The following is a description of a gene set: Human Gene Set: TESAR_ALK_TARGETS_HUMAN_ES_4D_DN The application of human embryonic stem (ES) cells in medicine and biology has an inherent reliance on understanding the starting cell population. Human ES cells differ from mouse ES cells and the specific embryonic origin of both cell types is unclear. Previous work suggested that mouse ES cells could only be obtained from the embryo before implantation in the uterus. Here we show that cell lines can be derived from the epiblast, a tissue of the post-implantation embryo that generates the embryo proper. These cells, which we refer to as EpiSCs (post-implantation epiblast-derived stem cells), express transcription factors known to regulate pluripotency, maintain their genomic integrity, and robustly differentiate into the major somatic cell types as well as primordial germ cells. The EpiSC lines are distinct from mouse ES cells in their epigenetic state and the signals controlling their differentiation. Furthermore, EpiSC and human ES cells share patterns of gene expression and signalling responses that normally function in the epiblast. These results show that epiblast cells can be maintained as stable cell lines and interrogated to understand how pluripotent cells generate distinct fates during early development. species: Homo sapiens from publication Tesar PJ, Chenoweth JG, Brook FA, Davies TJ, Evans EP, Mack DL, Gardner RL, McKay RD (PMID 17597760) Genes down-regulated in hES cells (human embryonic stem cells) after treatment with the ALK inhibitor SB-431542., and this is the list of marker genes: CRIPTO, LEFTY1, NODAL, MYC, LEFTY2 (NCBI Gene Id 96286), NANOG